The following is a description of a gene set: Mouse Gene Set: GOBP_GLUCOSAMINE_CONTAINING_COMPOUND_METABOLIC_PROCESS The chemical reactions and pathways involving glucosamine-containing compounds (glucosamines). species: Mus musculus, and this is the list of marker genes: Chil4, Ogt, Chst3, Chst4, Chil6, Chit1, Nanp, Chst1, Gnpnat1, Extl2, Gne, Ovgp1, Gnpda2, Chia1, Hexb, Mgat3, Renbp, Chst7, Chst5, Gfpt1, Chil3, Gnpda1, Oga, Nagk, Chst2, Ctbs, Amdhd2, Chi3l1, Chil5